The following is a description of a gene set: from publication Naba A, Clauser KR, Hoersch S, Liu H, Carr SA, Hynes RO (PMID 22159717) Genes encoding proteins affiliated structurally or functionally to extracellular matrix proteins One hallmark of ECM proteins is their domain-based structure. Exploiting this characteristic, we established a list of diagnostic InterPro domains commonly found in ECM proteins. We know that some of the domains used to select positively for ECM proteins are also found in transmembrane receptors and proteins involved in cell adhesion (growth factor receptors, integrins, etc) that do not belong to the ECM. These families of proteins also display a subset of specific domains and transmembrane domains incompatible with definition as Mouse Gene Set: NABA_ECM_AFFILIATED species: Mus musculus, and this is the list of marker genes: Sema4c, Clec2i, Cd209d (NCBI Gene Id 170779), Clec9a, Muc21, Clec1a, Clec3a, Itln1, Reg1, Muc1, Muc19, Sema3g, Reg3b, Sema6b, Clec12a, Anxa3, Elfn2, Lgals9, Anxa11, Clec1b, Reg2, Gpc4, Clec7a, C1qtnf7 (NCBI Gene Id 78661), Sema3a, Mucl1, Lgals2, Prol1, Frem3, C1qa, Hpx, Clec3b, Mbl2, Sftpd, C1ql1, Muc13, Clec2e, Cspg5, Clec4n, Clec4a1, Anxa10 (NCBI Gene Id 26359), Mbl1, C1qtnf9, Colec12, Clec4e, Clec4a3, Anxa7, Grem1, Reg3g (regenerating islet-derived 3 gamma), Muc4, Muc16, Gpc1, Lman1, Sftpb, Sftpc, Cd209b, C1qb, Gpc3, Lgals3, Lgalsl, Fcna, Clec4d, Sema3f, C1qtnf1, Plxnb1, C1qc, Fcnb, Frem1, Sema3d (NCBI Gene Id 74345), C1qtnf4, Colec10, Clec5a, Clec4a4, Sema4f, Clec14a, Clec2l, Plxna4, Clec4b2, Clec4a2, Anxa9, C1qtnf6, C1qtnf3, C1ql4, Gpc6, Clec2h, Muc15, Sdc1, C1ql2, Sema6d, Plxdc1, Sema4b, Anxa8, Sdc4, Sema6c, C1qtnf5, Clec2j, Muc5b, Sema7a, Anxa4, Gpc2, Sema6a, Plxnc1, Ovgp1, Emcn, Lgals12, Anxa1, Clec12b, Colec11, Clec4b1, Sema5b, Lman1l, Sema4d, Parm1, Plxna1, Lgals7, Anxa6, Muc17 (mucin 17, cell surface associated), C1qtnf2, Clec10a, Plxnd1, Plxnb2, Sftpa1, Anxa5, Clec11a, Zpld2, Sdc3, Clec4g, Plxnb3, Lgals4, Elfn1, Muc5ac, Sdc2, Clec18a, Cspg4, Anxa13, Muc6, Clec2d, Plxdc2, Sema5a, Lgals1, Sfta2, Grifin, Sema3b, Muc20, Anxa2, Sema3c, Gpc5, Plxna2, Clec2g, Sema4g, Cd209a, C1ql3, Frem2 (Fras1 related extracellular matrix protein 2), Lgals8, Sema4a, Clec4f, Muc2, Reg4, Sema3e, Plxna3, Reg3d, Reg3a